The following is a description of a gene set: Genes predicted to be targets of miRBase v22 microRNA mmu_miR_344d_2_5p in miRDB v6.0 with MirTarget v4 prediction scores > 80 (high confidence targets). Mouse Gene Set: MIR_344D_2_5P species: Mus musculus from publication Chen Y, Wang X (PMID 31504780), and this is the list of marker genes: Rnf220, Timm8a1, Muc21, Hspb7, Ccdc91, Palld, Mecp2, Gdi2, Azin1, Prdm16 (NCBI Gene Id 70673), Prss23, Ttc28, Pnn, Folr1, Hnrnpm, Zeb1, Acta2, Qrich1 (glutamine-rich 1), Mdga2, Bend5, Paqr7, Ntng1, Pdss1, Mfn1, Kifc2, Trpm3, Nfia, Rab14, Nol4l, Dipk2b, Cdc42bpa, Qki, Cdkal1, Efcab6, Cacna2d2, Prm1, Med19, Arhgef38, Zfp386, Gpr83, Tmem117, Mgat4d, Sox12, Dpysl5, 4921539E11Rik, Rnf43